The following is a description of a gene set: Catalysis of the hydrolysis of the terminal (1->2)-linked alpha-D-mannose residues in an oligo-mannose oligosaccharide. species: Homo sapiens Human Gene Set: GOMF_MANNOSYL_OLIGOSACCHARIDE_1_2_ALPHA_MANNOSIDASE_ACTIVITY, and this is the list of marker genes: MAN1B1, EDEM2, MAN1A2, EDEM3, EDEM1, MAN1C1, MAN1A1